The following is a description of a gene set: Mouse Gene Set: MIR_669F_5P species: Mus musculus from publication Chen Y, Wang X (PMID 31504780) Genes predicted to be targets of miRBase v22 microRNA mmu_miR_669f_5p in miRDB v6.0 with MirTarget v4 prediction scores > 80 (high confidence targets)., and this is the list of marker genes: Cdk17, Kpna1 (karyopherin subunit alpha 1), Cd86, Ikzf4, Maml2, Bcor, Stt3b, Nppc, Pcdh10, Nxph1, Gm5141 (predicted gene 5141), Map7d1, Zfp59, Ttc28, Lrrtm1, Tbc1d13 (NCBI Gene Id 70296), H2-D1, Rabgap1l, Sh3kbp1, Gabrr1, Brwd3, Myrip, Lrrc74b, Nrxn1, Lcp2, Tor1aip1, Bcl2, Lhx2 (LIM homeobox protein 2), Porcn, Gm3604, Aldh1l2, Mxra8, 2510009E07Rik, Has2, Rad52, Atxn1, Capn3, 4931406C07Rik, Aff4, Ppp2r2d, G3bp2, Atad2, Dmd, Cp, Trpc6, Pum2, Pde3a, Insyn2b, Zfp1008, Dpysl2, Clec2l, 5730455P16Rik (RIKEN cDNA 5730455P16 gene)